The following is a description of a gene set: Any process that modulates the frequency, rate or extent of vasculature development. Mouse Gene Set: GOBP_REGULATION_OF_VASCULATURE_DEVELOPMENT studied in species Mus musculus, and this is the list of marker genes: Nras, Rapgef3, Rhoj, Hmgb1, Or10j5, Atf2, Cd160, Adgrb3, Ptger4, Tlr3, Hipk2, Ago2, Tjp1, Il1a, Sema3e, Sema4a, Tnfrsf1a, Adam10, Ramp2, Plcg1, Foxc1, Tgfbr1, Apela, Cela1, Lrg1, Notch4, Col4a2, Sfrp2, Reck, Prkd2, Wnk1, Thbs4, Anxa3, Naxe, Agt, Mtdh (NCBI Gene Id 67154), Cxcr3, Cldn5, Ptn, Thbs2, Rock2, Mmp9, Tie1, Gata2, Cxcl10, Emilin2, Camp, Ccbe1, Adgrb2, Creb3l1, Lep, Il10, Gata4, Tek, Ghsr, Alox5, Lgals3, Pik3cg, Adam12, Hmga2, Ntrk1, Pml, Brca1, Wars1, Ptpn6, Jcad, Bmper, Serpine1, Gab1, Gata6, Ctsh, Fbln5, Hc, Cnmd, Adgrb1, Emc10, Col4a3, Wnt5a, Rgcc, Qki (quaking, KH domain containing RNA binding), Krit1, S2bpcox16, Acvrl1, Gdf2 (NCBI Gene Id 12165), Shc1, Itgb2, Hgs, Cx3cr1, Aqp1, Ago1, Ppp1r16b, Pdcd6, Abl1, Ccl11, Vegfa, Ceacam1, Angpt2, Sh2b3, Igf2, Sema5a, Prkcb, Sirt6, Ets1, Rras, Cysltr2, Cd59a, Adamts1, Optc, Cdh5, Runx1, Hhex, Cd40, Stard13, Spred1, Glul, Foxo4, Sp1, Ppp1r15a, Sphk1, Nr2e1 (NCBI Gene Id 21907), Tnf, Plk2 (polo like kinase 2), Cemip2, Tgm2, Il1b, Akt3, Emp2, Ptgis, Nrp1, Itgax, Dll1, Itgb8 (integrin beta 8), Rock1, Prl7d1, Fgf1 (fibroblast growth factor 1), Add1 (NCBI Gene Id 11518), Erap1, Psg22, Ecm1, Jup, Isl1, Cysltr1, Foxj2, Aggf1, Epn2, Tspan12, Tgfb2, Tbxa2r, F3, Tnn (NCBI Gene Id 329278), Ninj1, Mir329, Plxnd1, Ngp, Sema6a, Mdk, Vash2, Synj2bp, Slc12a2, Mir24-2, Tcf4, Rnh1, Stat1, Btg1, Prok1, Tafa5, Sec1, Pxn, Cma1, Pdcd10, Mapk7, Efna1, Fgf18, Cd36, Wars2, Emilin1 (elastin microfibril interfacer 1), Epha1 (Eph receptor A1), Nos3, Mir27a, Tnmd, Gpr4, Mir23a, Aplnr, Epn1, Adm, Minar1 (membrane integral NOTCH2 associated receptor 1), Gadd45a, Cybb, E2f2, Pik3cb, Shh, Smoc2, Angptl3, Ecscr, Adm2, Vegfc, Klf2, Nodal, Htatip2, Fkbpl, Egln1, Ptk2b, Pik3cd, Il17f, Epha2, C5ar1, Fgf2, Cxcr4, Pgf, Ism1, Sirt1, Cd34, Pdcl3, Gm28729, Adrb2 (NCBI Gene Id 269028), Sparc (secreted acidic cysteine rich glycoprotein), Eng, Pgk1, Prkd1, Slc39a12, Angpt4, Adgra2, Dsg2, Ngfr, Pdpk1, Zc3h12a, Ccr2, Rtn4, Kdr, Ccl2, Ccn6, Cxcl12, Mecp2, Nfe2l2, Flt1, Uts2r, Tgfb1, Hyal1, S100a1 (NCBI Gene Id 99575), Mir27b, Mir24-1, Tspan18, Pak4, Smad1, Zfp354c, Sp100, C3ar1, Vegfb, Pik3r6, Sash1, Hrg, Pparg, Sulf1, Ccl5, Hspb1, Amot, Grem1, Clic3, Hk2, Pf4, Chi3l1, C3, Plg, Crhr2, Mir23b, Klf4, Ghrl, Itga5, Vash1, Tgfbr2, Apoh, Nf1, Hoxa5, Itgb1, Ccl24, Jak1, Hspb6, Sars1, Mydgf, Foxc2, Grn, Rela, Stim1, Itgb2l, Tert, Lif, Tnfrsf12a (NCBI Gene Id 98086), Ptprm, Hif1a, Cyp1b1, Hhip, Uts2, Stat3, Pde3b, Fut1, H2-M3, Id1, Prl2c2, Pkm, Gtf2i, Thbs1, Adamts9 (NCBI Gene Id 69070), Atp2b4, Fyn, Xbp1, Ccm2, Ccr3, Hgf, Abcc8, Prkca, Itgb3, Ctnnb1, Stab1, Wnt4, Agtr1a, Dcn, Ddah1, Hmox1, Rhob (ras homolog family member B), Dab2ip, Fasl, Serpinf1, Jmjd8, Yjefn3, Angptl7, Cxcr2 (C-X-C motif chemokine receptor 2), Efna3, Spry2